Given this list of marker genes ORC2, SEC23IP, IGHV1-69, IGLV2-14, PRDX3 (peroxiredoxin 3), JPT2, CD163, CXCL8, DDX17, CCT4 (NCBI Gene Id 10575), SHQ1, GADD45B, NUP62, LPCAT4, CAD, EZR, PREPL, here is a description of the gene set: Genes distinguishing between MGUS (monoclonal gammopathy of undetermined significance) and multiple myeloma (MM) samples. Multiple myeloma (MM) is the most common form of plasma cell dyscrasia, characterized by a marked heterogeneity of genetic lesions and clinical course. It may develop from a premalignant condition (monoclonal gammopathy of undetermined significance, MGUS) or progress from intramedullary to extramedullary forms (plasma cell leukemia, PCL). To provide insights into the molecular characterization of plasma cell dyscrasias and to investigate the contribution of specific genetic lesions to the biological and clinical heterogeneity of MM, we analysed the gene expression profiles of plasma cells isolated from seven MGUS, 39 MM and six PCL patients by means of DNA microarrays. MMs resulted highly heterogeneous at transcriptional level, whereas the differential expression of genes mainly involved in DNA metabolism and proliferation distinguished MGUS from PCLs and the majority of MM cases. The clustering of MM patients was mainly driven by the presence of the most recurrent translocations involving the immunoglobulin heavy-chain locus. Distinct gene expression patterns have been found to be associated with different lesions: the overexpression of CCND2 and genes involved in cell adhesion pathways was observed in cases with deregulated MAF and MAFB, whereas genes upregulated in cases with the t(4;14) showed apoptosis-related functions. The peculiar finding in patients with the t(11;14) was the downregulation of the alpha-subunit of the IL-6 receptor. In addition, we identified a set of cancer germline antigens specifically expressed in a subgroup of MM patients characterized by an aggressive clinical evolution, a finding that could have implications for patient classification and immunotherapy. studied in species Homo sapiens from publication Mattioli M, Agnelli L, Fabris S, Baldini L, Morabito F, Bicciato S, Verdelli D, Intini D, Nobili L, Cro L, Pruneri G, Callea V, Stelitano C, Maiolo AT, Lombardi L, Neri A (PMID 15735737) Human Gene Set: MATTIOLI_MGUS_VS_MULTIPLE_MYELOMA